The following is a description of a gene set: Mouse Gene Set: GOBP_ECTODERM_FORMATION studied in species Mus musculus The formation of ectoderm during gastrulation., and this is the list of marker genes: Foxa2, Lhx1, Pou5f1, Elf5 (NCBI Gene Id 13711), Ets2, Fzd7 (frizzled class receptor 7)